The following is a description of a gene set: Neonatal seizure is a seizure type that occurs in neonatal period and is characterized by an electrographic event with sudden, repetitive, evolving stereotyped waveforms with a beginning and an end. This event can be associated or not with a clinical manifestation. studied in species Homo sapiens Human Gene Set: HP_NEONATAL_SEIZURE_WITH_ELECTROGRAPHIC_CORRELATE Neonatal seizure with electrographic correlate, and this is the list of marker genes: SCN2A, KCNQ2, SCN8A, PRRT2, KCNQ3